Given this list of marker genes PPP1R3A, ENPP1 (NCBI Gene Id 5167), SELENOS, INS, PRKAG3, PPP1R3B, IRS1, GRB10, PPP1CA, EPM2AIP1, PPP1R3C, MIR15B, PTH, IRS2, INSR (insulin receptor), PPP1R3E, PPP1R3D, GCK, IGF1, AKT2, PPP1R3F, GSK3B, PASK, MIR1271 (NCBI Gene Id 100302203), MIR195, AKT1, SORBS1, INPP5K, IGF2, PPP1R3G, GSK3A, DYRK2, here is a description of the gene set: Any process that modulates the frequency, rate or extent of the chemical reactions and pathways resulting in the formation of glycogen. Human Gene Set: GOBP_REGULATION_OF_GLYCOGEN_BIOSYNTHETIC_PROCESS studied in species Homo sapiens